The following is a description of a gene set: Genes negatively differentially expressed in cell type: γδ T cell upon treatment with cytokine: IFN-ε in mouse lymph nodes in vivo. Cytokines mediate cell-cell communication in the immune system and represent important therapeutic targets. A myriad of studies have highlighted their central role in immune function, yet we lack a global view of the cellular responses of each immune cell type to each cytokine. To address this gap, the authors created the Immune Dictionary, a compendium of single-cell transcriptomic profiles of more than 17 immune cell types in response to each of 86 cytokines (>1,400 cytokine-cell type combinations) in mouse lymph nodes in vivo. A cytokine-centric view of the dictionary revealed that most cytokines induce highly cell-type-specific responses. For example, the inflammatory cytokine interleukin-1β induces distinct gene programmes in almost every cell type. A cell-type-centric view of the dictionary identified more than 66 cytokine-driven cellular polarization states across immune cell types, including previously uncharacterized states such as an interleukin-18-induced polyfunctional natural killer cell state. studied in species Mus musculus from publication Cui A, Huang T, Li S, Ma A, Pérez JL, Sander C, Keskin DB, Wu CJ, Fraenkel E, Hacohen N (PMID 38057668) Mouse Gene Set: CUI_T_CELL_GD_IFNE_RESPONSE_DN, and this is the list of marker genes: Klf2, Uba52, Hspa1b, Rhob, Jun, Fos, Junb, Hspa1a, Nr4a1